Given this list of marker genes MICA, ULBP3, ULBP2, HLA-E, RAET1G, MICB, ULBP1, RAET1E, here is a description of the gene set: species: Homo sapiens Human Gene Set: GOMF_NATURAL_KILLER_CELL_LECTIN_LIKE_RECEPTOR_BINDING Binding to a lectin-like natural killer cell receptor.